Given this list of marker genes NDUFA4, NDUFS2, NDUFA11, NDUFA2, NDUFS3, NDUFB1, MT-ND3 (NCBI Gene Id 4537), NDUFA5, MT-ND2, MT-ND1, NDUFA10, NDUFA8, NDUFB4, NDUFS8, NDUFB8, NDUFA12, NDUFA9, NDUFV3, NDUFB5, NDUFS1, NDUFA3, MT-ND6, NDUFV1, MT-ND4, NDUFS5, MT-ND5 (mitochondrially encoded NADH:ubiquinone oxidoreductase core subunit 5, NCBI Gene Id 4540), NDUFB2, NDUFB9, NDUFA13, NDUFB11, NDUFB7, NDUFB10, NDUFS7, NDUFS4 (NADH:ubiquinone oxidoreductase subunit S4), NDUFA6, NDUFA7, NDUFC2, NDUFAB1, NDUFS6, NDUFA1, NDUFV2, NDUFB6, NDUFC1, NDUFB3, PINK1, here is a description of the gene set: Human Gene Set: KEGG_MEDICUS_VARIANT_MUTATION_INACTIVATED_PINK1_TO_ELECTRON_TRANSFER_IN_COMPLEX_I Mutation-inactivated PINK1 to electron transfer in Complex I. Pathway ID: N01043. Pathway type: Variant. Pathway class: nt06463 Parkinson disease. Pathway Definition from KEGG: PINK1* -| CxI -> Q species: Homo sapiens